The following is a description of a gene set: Genes positively differentially expressed in cell type: B cell upon treatment with cytokine: M-CSF in mouse lymph nodes in vivo. species: Mus musculus Mouse Gene Set: CUI_B_CELL_M_CSF_RESPONSE_UP from publication Cui A, Huang T, Li S, Ma A, Pérez JL, Sander C, Keskin DB, Wu CJ, Fraenkel E, Hacohen N (PMID 38057668) Cytokines mediate cell-cell communication in the immune system and represent important therapeutic targets. A myriad of studies have highlighted their central role in immune function, yet we lack a global view of the cellular responses of each immune cell type to each cytokine. To address this gap, the authors created the Immune Dictionary, a compendium of single-cell transcriptomic profiles of more than 17 immune cell types in response to each of 86 cytokines (>1,400 cytokine-cell type combinations) in mouse lymph nodes in vivo. A cytokine-centric view of the dictionary revealed that most cytokines induce highly cell-type-specific responses. For example, the inflammatory cytokine interleukin-1β induces distinct gene programmes in almost every cell type. A cell-type-centric view of the dictionary identified more than 66 cytokine-driven cellular polarization states across immune cell types, including previously uncharacterized states such as an interleukin-18-induced polyfunctional natural killer cell state., and this is the list of marker genes: Exoc3, Zfp422, Arpc4, R3hdm4, AI480526, Sptssa, Mettl26, Sf3b4